Given this list of marker genes TOMM70 (translocase of outer mitochondrial membrane 70), TMPRSS2, NDUFAF1, ACAD9, ACE, PHB2, NDUFB9, REN, IKBKE, TLR3, ECSIT, NOX1, AGTR1, STING1, AGTR2, IRF3, NFKB2, ACE2, IFIH1, TLR7, TICAM1, MAVS, BCS1L, TRAF3, CGAS, TRAF6, RIGI, IRF7, PHB1, NFKB1 (nuclear factor kappa B subunit 1), CTSL, TBK1, NLRX1, here is a description of the gene set: Mitochondrial immune response to SARS-CoV-2 Human Gene Set: WP_MITOCHONDRIAL_IMMUNE_RESPONSE_TO_SARSCOV2 species: Homo sapiens